Given this list of marker genes ASPA, ABCC8, RPE65, AP3B1, MCM4, RNF168, KCNJ11, CDH2, POLRMT, ALB, ACTB, TANGO2, IARS1, RNU4-2, TCF12 (transcription factor 12), TBX2, ATRIP, PDP1, SF3B2, RRAS2, PTF1A, WDR26, ATR (NCBI Gene Id 57307), AMT, TSPAN12, SEC61A1, SPATA7, TBX4, FTCD, NFE2L2 (NCBI Gene Id 4780), PLK4, ABCA2, PHKB, SNF8, NUP85, MAP1B, SOX3, ADNP, LRAT (NCBI Gene Id 9227), CENATAC, ZNF462, NSMCE3, SOX9, DHTKD1, CDC6, FZD4, RBBP8, TOP3A, RAI1, NARS2, PLCB4, ACAD8, NDP, B4GALT7, CTNNB1, PCNT, TPP2, GNB2, SIX1, ZNF408, PRKAR1A, ERMARD, CEP152, ATP5F1B, TMEM163, COG1, DOLK, GJA1, PEPD, NONO, TRAIP, PLP1, MT-TK, EIF4A2, CENPE, ALDH4A1, LRP5, AASS, LCA5, POLR1A, DNA2, EYA1, OCRL, DBR1, CTSK, here is a description of the gene set: studied in species Homo sapiens Human Gene Set: HP_MILD_GLOBAL_DEVELOPMENTAL_DELAY A mild delay in the achievement of motor or mental milestones in the domains of development of a child. Mild global developmental delay